Given this list of marker genes CCDC22, CWC22, CNTROB, ADCY10, TIAM1, TMIGD1, VWA8, RGS13, WDR77, GPR34, CNEP1R1, PM20D1, TDRD12, PIK3CD, LRP2BP, PRDM16, SMARCC1, GXYLT2, THRAP3, GOLT1A, CHORDC1, PILRA, ZNF627, GNAS, ZNF475 (zinc finger protein 475), FCHO2, NSF, SLC6A11, CHMP4C (NCBI Gene Id 92421), MT4, MYH6 (myosin heavy chain 6), LDLR, CPNE7, LRTM2, ELAVL4, CHCT1, SH3BP1, PROS1, TET3, ATG2B, RUNX3, F2, TMEM212, OLFM3, USP27X, PHTF2, SPATC1L, USP9Y, LRFN5, LRRC52, SLC12A1, ASPH, SMARCD2, ITGB3, SLC6A12, DMRTA1, RPS16, TXN, GSC, CNOT6, FKBP1A, LYRM7, CLCA4, PNLIPRP2, ECM1, ZSCAN10, SLC17A3, RXFP2, ARFRP1, LIN28B, UBE2G1, LRRC3, CEP170B, ERN1, IL17A, ARHGAP10, CYP19A1, TAGLN3, TMEM229A, ARL14, WT1, DHODH, AHRR, SLCO4A1, LHFPL6, CPN1, DGKI, ST3GAL6 (ST3 beta-galactoside alpha-2,3-sialyltransferase 6), RAB11FIP5, BCAT1, ST6GALNAC5, TBCEL, AIRN, SCAI, TXNRD3, CMTR2, GAD1, ADGRA2, EIF3E, MEP1B, DDC, FPR2, DNMT3A, SOX30, KDM8, GOLGA4, UQCRC2, CABYR, PARP14, INS (NCBI Gene Id 3630), CFAP53, ANK3, ZNF420, FAM163B, PRR16, FAM86B2, OTOR, CNTN6, MTREX, S100A5, DHFR, PEDS1, PCDH8, WDR86, ELOVL7, TNNI3, TMOD4, PRKCA, F13B, TBCK, CRY1, GULP1, INHA, LHPP, HSD3B1, DYNLL2, ZNF23, LMAN2, KPLCE, CRX, DUT, MYO6, ACTR3B, STK40, TEX22, SMARCA1, VAX1 (ventral anterior homeobox 1), PLA2G15, GPR137B, CEP15, SORBS1, IER3, RIPOR1, SEPTIN8, WDR25, PRKD1, SLCO1C1, OSBPL7, DIO3OS, GML, TRAF7, SH3KBP1, AKAP4, STXBP4, RGS10, B9D1, PAFAH2, RORC, N4BP1, SULF1, C12orf71, SATB2, TNFSF14, TOP3B, WFDC2, ABCC2, ABCC8, WNK3, TAOK3, DNAAF9, LCN12, C12orf75, MTMR6, CLEC1A, ME3, RHOA, MROH3P, KCTD17, DONSON, SET, CYB561, CNTN3, KDM5C, IFTAP, SNAI3, NDRG4, PPARGC1B, TREML4, here is a description of the gene set: from publication Ventre E, Brinza L, Schicklin S, Mafille J, Coupet CA, Marçais A, Djebali S, Jubin V, Walzer T, Marvel J (PMID 22942430) Human Gene Set: GSE32423_CTRL_VS_IL7_MEMORY_CD8_TCELL_DN Effects of IL-4 on CD8 T cells functions are largely unknown. IL-4 induces survival and proliferation of CD8 T cells, but several studies suggest that IL-4 could also affect several functions of CD8 T cells such as cytotoxicity. Our team has shown that IL-4 repress the expression of Ccl5 in vitro. To define more precisely the impact of IL-4 on CD8 T cells, we performed a whole genome expression microarray analysis of naive and memory CD8 T cells cultured in presence or absence of IL-4. This approach allowed us to define the IL4-gene-expression signature on CD8 T cells. Genes down-regulated in comparison of memory CD8 T cells versus those treated with IL7. species: Homo sapiens